The following is a description of a gene set: studied in species Homo sapiens Any process that increases the rate or frequency of epithelial cell proliferation that results in the lung attaining its shape. Human Gene Set: GOBP_POSITIVE_REGULATION_OF_EPITHELIAL_CELL_PROLIFERATION_INVOLVED_IN_LUNG_MORPHOGENESIS, and this is the list of marker genes: CDC42 (NCBI Gene Id 998), FGFR2, WNT2, FOXP2, FGF7, HMGA2, SRSF6